The following is a description of a gene set: Mouse Gene Set: GOCC_RIBBON_SYNAPSE Type of synapse characterized by an electron-dense ribbon, lamella (bar) or spherical body in the presynaptic process cytoplasm. species: Mus musculus, and this is the list of marker genes: Rapgef3, Hspa8, Dnm1, Cltc, Camk2d, Sh3gl2, Bsn, Rims2 (regulating synaptic membrane exocytosis 2), Ctbp2, Amph, Cacna1d, Myo6, Nlgn2, Atp2a2, Lrrtm4, Cplx3 (complexin 3), Nphp4, Pclo, Otof, Dag1, Kif3a, Arfgap3, Atp2b2, Cdh23, Egflam, Unc13b, Pacsin1, Snap25, Atp2b1, Diaph3, Cacnb2, Iqsec2